Given this list of marker genes Dazap2, Angpt4, Bcl10, Cdk5r2, Btc, Iqgap1, Nek9, Ccdc88a, Fam20a (NCBI Gene Id 208659), Camk2n1, Mob3c, Ccne1, Htr2a, Smcr8, Tcl1b1, Rptor, Ccna1, Vac14, Ccnk, Vegfa, Parva, Cdk5r1, Ppp2r5a, Cav1, Ccno, Ccnl1, Akt1s1, Cdkn2b, Ccng1, Topbp1, Ttn, Mob2, Epgn, Mob1b, Hspa5, Malt1, Calm1, Prkd1, Ins1, Acvr2b, Rictor, Rac2, Ccnb3, Hexim1, Ywhab, Cab39l, P2rx7, Ccnc, Spdya, Prkag1, Ccni, Cd40lg, Fermt2, Dele1, Itprip, Hexim2, Ajuba (ajuba LIM protein), Cdkn1a, Tesc, Mbip, Prex1, Stap1, Itsn1, Acsl1, Akap11, Socs5, Afap1l2, Akt1, Insr, Bccip, Map3k13, Sh3bp5l, Calm2, Pde8a, Areg, Tcl1b2, Cks2, Prkar1b, Ankle2, Spry4, Ahsg, Pak1ip1, Map3k12, Ercc6, Cdkn1b, Irs2, Dbf4, Etaa1, Cdkn2a, Dus2, Ltk, Npm1, Map2k1, Mt3, Als2, Gckr, Prkch, Pim1, Alkal2, Deptor, Tab1, Gstp1, Ccnt1, Mlst8, Stradb, Irgm2, Trib2, Hspb1, Ins2, Nckap1l, Tcl1, Agap2, Apc, Ccnj, Ankrd42, Gskip, Mtcp1, Klf4, Tcl1b4, Dusp22, Calm3, Tsacc, Ppef2, Grm5, Htra2, Ccna2 (NCBI Gene Id 99481), Tcl1b3, Igtp, Dgkq, Rheb, Ccnd3, Elp4, Ccnjl, Rack1, Ccne2, Atad3a, Grem1, Sav1, Egf, Igf1, Rhoh, Casp3, Cep43, Ltf, Cks1b, Prkrip1 (NCBI Gene Id 66801), Pik3r6, Gprc5d, Ccnb1-ps, Adipoq, Gcn1, Macroh2a1, Trem2, Dnajc3, Abi1, Spred1, Nck1, Parp8, Rgcc, Smo, Pak2, Tgfa, Spred2, Prex2, Samd15, Ankrd54, Kidins220, Inka1, Rubcn, Wdr91, Taok1, Wdr81, Cdkn2d, Bmp2, Cdc37, Inka2, Inca1, Hsp90ab1, Igf2, Ibtk (NCBI Gene Id 71427), Mstn, Daxx (Fas death domain-associated protein), Rplp1, Camk2n2, Nos2, Nrg1, Pkib, Pmp22, Parp16, Ccnq, Ccnf, Bmp4, Eef1a1, Pik3r3, Lilrb4a, Cdkn2c, Mnat1, Cit, Pik3ip1, Pkia, Tgfb1, Prkar2a, Irgm1, Ccnd2, Cab39, Sh3glb1, Trib3, Mob3a, Ereg, Cd24a, Ngf, Prkag2, Strada, Ccnd1, Ccl5, Gdf2, Atg14 (autophagy related 14), Prkra, Pkig, Wnk1, Ccnl2, Mapk8ip2, Il6st, Spry2, Socs3, Wars1, Fgf13, Cnppd1, Ccnh, Irs3, Atg13, Gprc5a, Parp6, Epo, Mob3b, Socs1, Slc27a1, Irs1, Ccng2, Dab2ip, Kat2b, Alk, Alkal1, Rad50, Hmgb1, Mob1a, Map3k20, Washc1, Ccny, Sh3bp5, Pik3ca, Cks1brt, Prkar1a, Lilrb4b, Ranbp2, Ccnb1, Lrp6, Prkag3, Trib1, Pik3r2 (NCBI Gene Id 18709), Cib1, Ddx3x, Lyn, Wnt11, Tcl1b5, Tom1l1, Lgals9, Gprc5b, Hyal2, Nolc1, Ptprc, Csnk2b (casein kinase 2, beta polypeptide), Pik3r1, Ghrl, Egfr, Nbn, Stk11, Gprc5c (NCBI Gene Id 70355), Erbb3, Rplp1rt, Hbegf, Qars1 (glutaminyl-tRNA synthetase 1), Tgfbr2, Elp3, Dusp19, D1Pas1, Pik3r5, Tex24, Lamtor3, Ccnb2, Bmp7, Chp1, Cdkn1c, Map2k2, Prkar2b, Ccnt2 (cyclin T2), here is a description of the gene set: studied in species Mus musculus Modulates the activity of a kinase, an enzyme which catalyzes of the transfer of a phosphate group, usually from ATP, to a substrate molecule. Mouse Gene Set: GOMF_KINASE_REGULATOR_ACTIVITY